Given this list of marker genes Ficd, Dnajb1, Cdk1, Dnaja1, Dnajb3, Nr3c1, Pacrg, Bag6 (NCBI Gene Id 80605), Cdkn1b, Dnajc2, Cyp1a1, Stau2, Prkn, Dnaja2, Dnajb6 (NCBI Gene Id 23950), Dnajc18 (DnaJ heat shock protein family (Hsp40) member C18), Ern1, Rps3 (ribosomal protein S3), Dnaja3, St13, Nod2, Sgtb, Cd24a, Mettl21a, Dnajb9, Tfrc, Dnajb14, Gpr37, Fkbp1a, Bax, Hdac8, Iqcg, Stub1, Dnaja4, Fgf1, Cyp27a1, Dnajb7, Sacs, Ppef2, Creb1, Pglyrp1, Rnf207, Dnajb2, Mvd (NCBI Gene Id 97454), Ttc4, Tsacc, Tsc1, Dnajb8, Cyp2b10, Nup62, Ppid, Dnajc10, Dnajb12, Cyp2e1, Spn, Dnajc8, Ago2, Snca, Stip1, Dmp1, Hikeshi, here is a description of the gene set: Binding to a Hsp70 protein, heat shock proteins around 70kDa in size. studied in species Mus musculus Mouse Gene Set: GOMF_HSP70_PROTEIN_BINDING